Given this list of marker genes STARD4, STARD6, FDX1, CYP11A1, FDXR, TSPOAP1, STAR, AKR1B1, STARD3NL (STARD3 N-terminal like), TSPO, FDX2, STARD3, here is a description of the gene set: part of: Metabolism of steroid hormones species: Homo sapiens The first process in the synthesis of all steroid hormones is the synthesis of pregnenolone from cholesterol. In this process, cholesterol mobilized from cytosolic lipid droplets or from lysosomes is transported to mitochondria and becomes localized to the inner mitochondrial membrane. Cholesterol transport appears to be rate-limiting for steroid hormone synthesis and its regulation, at the step of StAR-mediated traversal of the mitochondrial membrane, plays a central role in determining the amounts and identities of steroid hormones made in the body. In the inner mitochondrial membrane, cholesterol is converted to pregnenolone in a sequence of three reactions, all catalyzed by CYP11A (side chain cleavage enzyme). Finally, pregnenolone re-enters the cytosol. Reactome Pathway: Pregnenolone biosynthesis